Given this list of marker genes DOCK3 (NCBI Gene Id 1795), KCTD9, BICDL1, RGS16, SUFU, SETD3 (SET domain containing 3, actin N3(tau)-histidine methyltransferase), ARHGAP17, RNF19A, CCR4, SYK, DNAJB1, HACD2, FIBIN, FAM120A, LACC1, DIRAS1, ST3GAL5, NCKIPSD, QSOX2, PRRC2B, ZDHHC6, KIAA0513, ANKRD17, ASTN1, COPS2, EPHA3, SRGAP3, ENGASE, CABYR, GLI3, KLK6, PNPLA5, RASGEF1B, ARF6, AGO1, SPRY3, LDAH (lipid droplet associated hydrolase), MAP1B, NTNG1, MFSD9, RAPGEF1, C1orf21, RAB8B, POLR2J3, RFX7, CUL4A, CLTCL1, ADAR, USB1, CDCA2, SLC24A4, EGLN3, POLDIP2, PELI2, FBXL8, TTYH2, GRM1, ZC2HC1C, TEAD1, TM9SF3, AMZ1, PTPN11, KRBOX4, GUCA1ANB-GUCA1A, ALDH7A1, LSM14A, PDE2A, TSPEAR, TMEM62, SLC35F6, GLIS3, GRIK3, DNALI1, DNAAF9, PPARD, AMMECR1, WSB1, C1orf226, MUC6, CTNND1, TXNDC17, XYLB, ATXN1 (NCBI Gene Id 7912, ataxin 1), TUB, PCBP4, GPHN, ADNP2, FOXI1, KAT7, IGDCC3, GUCA2A, ANKS1A, ACIN1 (NCBI Gene Id 22985), BCL2L11, PPP4R3A, CACNA1A, CNOT2 (CCR4-NOT transcription complex subunit 2), SBNO1, ZNF862, CASTOR2, RRP7A, EBPL, NCS1, EIF5A2, PTCHD1, NT5C2, JCAD, UBE2W, SH3PXD2A, PSME4, MYT1L, CHMP7, PPP1R3B, USP20, IPCEF1, SSH1, CDS2, SMARCE1, PLAGL2, TOR2A, USP9X, SLC30A4, NATD1, ITPR2, PPIF, RGMA, RBM46, LBH, ATXN1L, EIF5A, TDRKH, ASB7, UHRF1, ABI2, CNTD1, TSPAN13, WNK3, SNX21, PDE3B, POM121, FAM217B, MKNK1, H2AJ, MTCL2, FAM168B, SPAST, CCND2, GSTM4, DNAJC6, SV2C, MLXIP, HCFC1R1, ADAM7, SLC35A3, SNTG2, DSE, NFATC2 (NCBI Gene Id 4773), AP2A2, ERLIN1, JAM2, ICE1, CNTFR, N4BP1, PTBP1, FAM98A, NMNAT2, ORAI2, SLC4A4, GMFB, DICER1, ST6GAL2, TMEM230, ZNF592, FHL1, NPC1L1, SFRP1, TPBG, here is a description of the gene set: Human Gene Set: MIR1205 Genes predicted to be targets of miRBase v22 microRNA hsa-miR-1205 in miRDB v6.0 with MirTarget v4 prediction scores > 80 (high confidence targets). from publication Chen Y, Wang X (PMID 31504780) species: Homo sapiens